Given this list of marker genes BCL11A, DPF2, SS18, BCL7C, SMARCC2, SMARCD3, BCL7A, PHF10, SMARCE1, ARID1A, SMARCC1, SMARCB1, SMARCA4, SMARCD1, BCL7B, ACTL6A (NCBI Gene Id 9178), SMARCD2, BCL11B, ACTB, here is a description of the gene set: A distinct BAF complex has been identified in mouse and human embryonic stem cells (esBAF) (Ho, Jothi et al, 2009, Ho, Ronan et al, 2009; Zhang et al, 2014; reviewed in Kadoch and Crabtree, 2015; Cenik and Shilatifard, 2021; Innis and Cabot, 2020). esBAF is characterized by the presence of SMARCA4/BRG1 to the exclusion of SMARCA2/BRM and SMARCD1/BAF60A. Where mouse esBAF uses only SMARCC1 (BAF155), human esBAF appears to contain both SMARCC1 (BAF155) and SMARCC2 (BAF170) (Ho, Ronan et al, 2009; Ho, Jothi et al, 2009; Zhang et al, 2014; Wade et al, 2015). esBAF also contains subunits BCL11A/B.<br>esBAF colocalizes with each of the pluripotency factors, and overexpression of esBAF subunits induces pluripotency in fibroblasts (Ho, Ronan et al, 2009; Ho et al, 2011).<br>As the assembly of human esBAF has not been examined in detail, this pathway is based on the modular assembly of cBAF, pBAF and ncBAF. Reactome Pathway: Formation of the embryonic stem cell BAF (esBAF) complex part of: SWI/SNF chromatin remodelers studied in species Homo sapiens